Given this list of marker genes HPD, BCS1L (NCBI Gene Id 7856), TFAM, FAH, TAT, SLC25A13, MPV17 (mitochondrial inner membrane protein MPV17), here is a description of the gene set: An increased concentration of tyrosine in the blood. species: Homo sapiens Human Gene Set: HP_HYPERTYROSINEMIA Hypertyrosinemia